Given this list of marker genes H2BC4, ABTB3, HEXA, PRMT5, AURKA, NFYB, BDKRB2, NR4A2, H2AC13, H2BC11, UGT1A5, H2BC15, H3C10 (NCBI Gene Id 8357), KCNB2, SNX2, TAF11L8, KATNA1, PGLYRP4, MICU1, ARNT2, SLC51A, H4C9, BUD23, TAF13, TENM2, MIGA2, H2BC9, BMP6, H2AC1, NFYC, PPP2CA, ATP1B2, H2BK1, ADD1, TAF8, JDP2, ATF2, ABCD2, H3-7, ERBB2, POLE3, TPM2, UBA2 (ubiquitin like modifier activating enzyme 2), NPAS1, ADD2, H3Y1, GABBR2, TRMT112, H2AB3, H3-5, TAF9, TAF6L, KATNB1, BAK1 (NCBI Gene Id 578), FZD4, TAF4B, QTRT1 (queuine tRNA-ribosyltransferase catalytic subunit 1), DRAP1, KCNK1, H2AB1, KCNK9, ZHX1, SEPHS1, SYT5, SLC7A8, H4C14, TAF11L4, NOLC1, SLC7A9, IRAK1, CAV2, TAF4, TFEB, TAF11L2, H4C5, CEACAM6, H2AL3, IKBKB (NCBI Gene Id 3551), UGT1A1, MICU3, TAF12, H2AC19, H2AC11, H3C13, H3C4, KCNK12, GTF2A2, RRAGC (NCBI Gene Id 64121), ABCG4, TAF11L13, H3C11, PEF1, SLC3A2, H4C4, H4C2, SDCBP, MAPK4, CREB3L3, TCF12, ATP1B1, H2BW1, MAPK6, DR1, ABCG5, H2AX, BCL11A, ADORA1, IL17A, VAPB, PHB2, TFAP2B, CYBB, ATF6, CFHR5, NPAS4, H2BC18, UGT1A10, FZD9, TCF4, GTF2A1, TAF11L11, CEBPB, HNF1A, FBXO7, YWHAH, SOS2, IRAK2, CD247, H3C12, SOS1, USF2, ITGA3, H2BC17, HIP1, PAFAH1B3, H2BC21, ARNT, H3-3A, H4C3, PDGFB, MACROH2A2, H2AJ, DGKD, BOK, SRI, PDCD6, ZBTB1, NFE2L1, H2BC7, SAE1, H3Y2, SLC7A13, IRAK3, SIM1, GCA, GADD45A, H2AC4, NPAS3, H3C3, ABCG1, H3C14, RRAGA, KRT25, TUBB2B, PGLYRP3, HSF1, METTL3, FXR1, PHB1, SMC3, TAF6 (TATA-box binding protein associated factor 6), NAE1, ZNF397, ZNF396, H4C12, H2BC5, KCNK5, KCNB1 (potassium voltage-gated channel subfamily B member 1), PDSS2, H2AP, H2BC12, CHRAC1, CENPT, SLC3A1, CYBA (NCBI Gene Id 1535, cytochrome b-245 alpha chain), H2AC15, RALGAPA1, SDCBP2 (NCBI Gene Id 27111, syndecan binding protein 2), ABTB2, TAF11L3 (NCBI Gene Id 646103), ATP1A2, TUBA1A, ITGB1, H4C11, TAF11L7, SNX1 (NCBI Gene Id 6642), TAF11L14, SUPT5H, RAN, H2AC25, TENM4, LSM5, HIP1R, JAM3, PSMF1, SMC1A, UGT1A9, ADRA1A, CHUK, IL12A, QTRT2, IKBKG, TOP2A, VAPA, PPP2R1A, H3C7, GPHB5, KRT1, ZHX3, SYT10, P4HB, UGT1A8, MICU2, MEF2C, H2AC7, BCL2, H2AC8, SIM2, PIK3R2, H2AC16, IL17F, AHR, H3C8, EXT1, UGT1A4, H2BC12L, TENM3, UGT1A6, TAF9B, KCNK17, H4C8, NEUROD1, H2BC6, H2BC8, ROPN1B, CLU, FXR2 (NCBI Gene Id 9513), H2BC19P, RCC1, CAV1, SRGAP2C, KRT10, SOHLH1, TPM1, POLE4, H2AC21, PIK3R1, RALGAPB, BIRC5, H4C16, MCL1, PML, TPM4, KCNK13, RUNX1, TCOF1, SLC51B, ADCY8, SUPT7L, FMR1, TP53, H4C13, BHLHE41, KCNK16, MACROH2A1, TENM1 (NCBI Gene Id 10405), H4C6, APOA2, TAF11L10, NR4A1, H4C1, EXT2, H2BC3, ADRA2A, RALGAPA2, H3C15, GABBR1, TLR4, ZHX2, UGT1A7, MIGA1, TAF11L9, ATP1A1, NEUROD2, H2BN1, BHLHA9, USF1, PAFAH1B2, ADRA2C, IL12B, APP, MEF2A, H2AC20, BHLHE40, SUPT3H, H2BC26, H2AC6, TAF11L6, IKZF3, H2AC17, H2AC12, CENPW, H2BW2, ABCG8, H2AZ1, H3-3B, YWHAE, BARD1 (BRCA1 associated RING domain 1), H2BC10, BAX, MLX, EPAS1, CENPS, TAF11L12, H3C2, ATF4, H2BC14, XBP1, H4C15, TLR6, H2BC1, H3C6, H2AB2, ERBB3, H2AC18, PDSS1, MLXIPL, PDGFA, UBA3, TAF1, TAF3, SYT1, LSM6, AGTR1, H2AZ2, CENPA, MTTP, H2BC13, GPHA2, ADRB1, ADRA1B, PAFAH1B1, SUPT4H1, UGT1A3, KCNK2, DDIT3, H4C7, ATF3, H3C1, CEACAM8, AOC3, RRAGD, TCF3, KCNK3, H3-4, TAF7, P2RY1, SOHLH2, HIF1A, CEBPA, TAF11, here is a description of the gene set: Human Gene Set: GOMF_PROTEIN_HETERODIMERIZATION_ACTIVITY Binding to a nonidentical protein to form a heterodimer. studied in species Homo sapiens